Given this list of marker genes TFAP2A (NCBI Gene Id 95131), ZIC2, RYR1, GNB2, CDKL5, TCF4, MYH8, KCNK4, SLC35C1, PPP1CB, IL6ST, UBE2A, ARID2, PBX1, RAD21, PURA (NCBI Gene Id 5813), MED12, DNMT3A, EZH2 (NCBI Gene Id 392834), TRPS1, SNX14, NSD1, CHSY1, INTS1, ATP6V1B2, COG8, JARID2, SETD5, PRKACB, HS2ST1, SMOC1, MGP, ARNT2, TAF4, SHOC2, ITPR1, NBN, PIGS, MAP3K7, TALDO1, RNU4-2, SPIN4, OCRL, EXT1, NAA10, PIGT, DPM2, SMPD4, AUTS2, H3-3A, DLK1, FBN1 (fibrillin 1), MEG3, OFD1, TOE1, NRCAM (neuronal cell adhesion molecule), EP300, DPYD, HRAS, EBF3, NAA20, H4C5, SUZ12, ZNF148, U2AF2, EFTUD2, KIF11, CREBBP, NOVA2, BRAF, PAM16, RTL1, H4C9, CBL, HSPG2 (heparan sulfate proteoglycan 2), NRAS, here is a description of the gene set: Accentuated, prominent philtral ridges giving rise to an exaggerated groove in the midline between the nasal base and upper vermillion border. species: Homo sapiens Deep philtrum Human Gene Set: HP_DEEP_PHILTRUM